Given this list of marker genes Itpkb, Ankrd11, Il18r1, Acp5, Serpinb1a, Ckb (NCBI Gene Id 12709), Mast3, Slc12a7, Cenpa, Klf4, Ncor1, Ctla2a, Entrep3, Pdcd4, Ramp3, Nr4a1, Arid1a, St8sia4, Selplg, Eef2, Zfp36, Klhl24, Sdc1, Nkg7, Ctsw, Cd7, Prr13, Ahnak, Septin9, Actn1 (actinin, alpha 1), Rgs2, Klf6, Sidt1, Zfp36l2, Satb1, Egr1, Arhgdib (NCBI Gene Id 11857), Gpx4, Arhgap45, Cd2, Myh9, Crip1 (cysteine-rich protein 1), Selenop, Stk17b, Thy1, Card19, H3f3b, Hmgb2, Emp3, Btg2, Cd53, Cebpb, Arl5c (NCBI Gene Id 217151), AB124611, Pde7a, Dgka (NCBI Gene Id 13139), Jak1, Lmo4, Ptpn18, Dusp5, Lyst, Klrk1, Ly6c2, H1f2, Kcnc1, Ddx5, Ubc, Cox7a2l, Akap13, Fosl2, Tcf7, Tagln2, Ablim1, Arl4c, Ramp1, Ankrd44, Txnip, Hsd11b1, Gpr183, Fos, Dap, Tecpr1, Cd28, Macf1, Mbnl1, Arhgap15, Tmem50a, Junb, Il7r, Rgs10, Txk, Rhob, Klrd1, Klf2, Ccl5, Ets1, Ypel3, Kif21b, Pnrc1, Dusp1, Tsc22d3, Saraf, Lsp1, Rasa3, Ctsd, Prex1, Neat1, Cd3e (NCBI Gene Id 12501), Neurl3, Adgre5, Smad7, Evl, Clk1, Gmfg, Hcst, S100a6, S1pr1, Fosb, Tspo, Tcp11l2, S100a10, Jund, Emb, Myl12b, Rasgrp2, here is a description of the gene set: Cytokines mediate cell-cell communication in the immune system and represent important therapeutic targets. A myriad of studies have highlighted their central role in immune function, yet we lack a global view of the cellular responses of each immune cell type to each cytokine. To address this gap, the authors created the Immune Dictionary, a compendium of single-cell transcriptomic profiles of more than 17 immune cell types in response to each of 86 cytokines (>1,400 cytokine-cell type combinations) in mouse lymph nodes in vivo. A cytokine-centric view of the dictionary revealed that most cytokines induce highly cell-type-specific responses. For example, the inflammatory cytokine interleukin-1β induces distinct gene programmes in almost every cell type. A cell-type-centric view of the dictionary identified more than 66 cytokine-driven cellular polarization states across immune cell types, including previously uncharacterized states such as an interleukin-18-induced polyfunctional natural killer cell state. Mouse Gene Set: CUI_T_CELL_GD_IL18_RESPONSE_DN Genes negatively differentially expressed in cell type: γδ T cell upon treatment with cytokine: IL-18 in mouse lymph nodes in vivo. from publication Cui A, Huang T, Li S, Ma A, Pérez JL, Sander C, Keskin DB, Wu CJ, Fraenkel E, Hacohen N (PMID 38057668) studied in species Mus musculus